Given this list of marker genes Poglut2, Uggt2, Epm2a, Poglut3, Gys2, Alg5, Ugcg, Poglut1, Ugt8a, Uggt1, Gyg1, Gys1, here is a description of the gene set: studied in species Mus musculus Catalysis of the transfer of a glucosyl group from UDP-glucose to an acceptor molecule. Mouse Gene Set: GOMF_UDP_GLUCOSYLTRANSFERASE_ACTIVITY